The following is a description of a gene set: The process in which an amino acid is transported across a membrane. species: Mus musculus Mouse Gene Set: GOBP_AMINO_ACID_TRANSMEMBRANE_TRANSPORT, and this is the list of marker genes: Slc38a6, Slc3a2, Septin2, Kcnj10 (NCBI Gene Id 16513), Psen1, Slc17a6, Arl6ip5, Arl6ip1, Slc1a7 (NCBI Gene Id 242607), Ntsr1, Slc1a4, Slc1a5, Slc38a10, Lrrc8a, Slc7a14, Slc6a11 (NCBI Gene Id 78727), Cln3, Slc7a12, Slc36a1, Prkcd, Cln8, Slc38a9, Slc38a5, Slc7a4, Slc6a18, Slc7a1, Ace2, Per2, Arhgef11, Slc25a2, Arg2, Slc7a9, Slc3a1 (NCBI Gene Id 20532), Slc36a2, Slc1a2, Slc7a11, Slc6a7, Rgs2, Slc25a22, Slc25a18 (solute carrier family 25 (mitochondrial carrier), member 18), Sfxn1, Slc38a2, Nat3, Slc38a8, Slc38a3, Slc6a5, Slc25a38, Sfxn2, Rgs4, Slc22a2, Slc38a7, Sfxn3, Slc1a6, Slc1a1, Gfap, Slc38a11, Slc15a4, Lrrc8c, Slc6a13, Slc66a1, Epm2a, Slc13a3, Slc38a1, Slc7a10, Slc43a1, Slc17a8, Slc7a7, Slc1a3, Slc43a2, Lrrc8d, Tnf, Itgb1, Slc6a14 (NCBI Gene Id 80646), Slc25a12, Lrrc8b, Arg1, Lrrc8e, Ttyh3, Slc7a15, Slc25a15, Slc7a6 (solute carrier family 7 (cationic amino acid transporter, y+ system), member 6), Slc6a1, Slc38a4, Slc25a29, Slc7a13, Ctns, Slc36a3, Ttyh1, Slc6a20b, Slc17a7, Slc36a4, Cltrn, Ucp2, Tspo2, Slc7a5, Nfkbie, Slc7a2, Slc6a9, Slc16a2, Mfsd12, Slc25a13, Slc6a6, Slc11a1, Grm1, Slc25a26, Ttyh2, Slc7a3 (solute carrier family 7 (cationic amino acid transporter, y+ system), member 3), Agt, Slc7a8, Grik1, Slc6a20a, Slc47a1, Slc22a4 (solute carrier family 22 (organic cation transporter), member 4)